The following is a description of a gene set: Mouse Gene Set: GOBP_REGULATION_OF_SEMAPHORIN_PLEXIN_SIGNALING_PATHWAY species: Mus musculus Any process that modulates the frequency, rate or extent of semaphorin-plexin signaling pathway., and this is the list of marker genes: Gdnf, Ncam1, Hand2, Mir23a, Mir23b, Mir27a, Mir27b